The following is a description of a gene set: Human Gene Set: HP_BONE_MARROW_MATURATION_ARREST Bone marrow maturation arrest Interruption of the procecss of diffferentiation of hematopoietic cells in the bone marrow, manifested by an increased proportion of immature cells in the bone marrow. studied in species Homo sapiens, and this is the list of marker genes: SRP68, SMARCD2 (SWI/SNF related, matrix associated, actin dependent regulator of chromatin, subfamily d, member 2), CSF3R, CLPB, JAGN1, SRP54, WAS, SEC61A1, FLNA